The following is a description of a gene set: The aggregation, arrangement and bonding together of a set of components to form a non-motile cilium. Mouse Gene Set: GOBP_NON_MOTILE_CILIUM_ASSEMBLY studied in species Mus musculus, and this is the list of marker genes: Hap1, Ift172, Vangl2, Bbs7, Arl13a, Kcnq1, Ift140, Togaram1, Mak, Intu, Gorab, Csnk1d, Rpgrip1l, Kcnf1, Dynll1, Tmem216, Bbs10, Mkks, Rpgrip1, Cep126, Bbs2, Cc2d2a, Disc1, Cc2d2b, Tmem80, Ahi1, Pqbp1, Kcnj10, Clcn4 (chloride channel, voltage-sensitive 4), Tmem107, Ift74, Stil, Pcdh15, Cep290 (centrosomal protein 290), Wrap73, Gfy, Pibf1, Ift122, Cep89, Pcm1, Tmem67, C2cd3, Arl13b, Mir129-2, Septin9, Mapre1, Cenpj, Enkd1, Ccdc13, Fuz, Ift80, Nphp3, Atmin, Ift57, Rp1, Ttc8, Kif3a, Htt, Ttbk2, Dync2h1, Ift88, Dctn1, Tbc1d32, Bbs1, Bbs4, Spag6l, Cep135, Mks1, Poc1a, Dnm2, Cep131, Tmem17, Ift52, Exoc5, Cep350